The following is a description of a gene set: species: Mus musculus Mouse Gene Set: chr19C2, and this is the list of marker genes: Tnks2, Gm46649, Gm4757, Pcgf5, Ppp1r3c, Gm24006, I830134H01Rik, Hectd2os, 1700122C19Rik, Gm50137, Fgfbp3, Btaf1 (B-TFIID TATA-box binding protein associated factor 1), Gm25268, Exoc6, Fra10ac1, Ffar4, Cpeb3, Pde6c, Htr7, Cyp26a1, F530104D19Rik, Rbp4, Gm25611, Ide, Ankrd1, Gm5248, Gm23300, Gm9042, Hhex, Gm9067, Marchf5, A830019P07Rik, Gm9066, Gm32027, Hectd2, Rpl10-ps6, Cyp26c1, Kif11, Gm41836, Myof, Rpp30, A330032B11Rik, Gm8663, Cep55 (NCBI Gene Id 74107)